The following is a description of a gene set: species: Homo sapiens Any process that modulates the frequency, rate or extent of T cell activation. Human Gene Set: GOBP_REGULATION_OF_T_CELL_ACTIVATION, and this is the list of marker genes: SMARCD3, CD274, CYRIB, SASH3, PLA2G2F, EBI3, BID, IL36B, IL10, KAT2A, RIPOR2, HLA-DRB3, LGALS9C, BTLA (B and T lymphocyte associated), HLA-DRA, NR5A2, CD40LG, DLG5, NLRP3, TNFSF14, FANCD2, BRD4, TRAF6, SELENOK, CD37, CD28, ADAM8, XBP1 (X-box binding protein 1), CD4, LCK, CD46, RAC2, PIK3R6, SIRPA, SHH, ZC3H8, RASGRP1, BCL10, VNN1, CD80, SHB, ZP4, MIR181C, FBXO38, RUNX3, IL20RB, IL12A, ZNHIT1, SMARCE1, SLC46A2, CD209, HES1, CRTAM, VTCN1, BCL6, KLHL22, SOX12, IL27, HLA-DRB4, LGALS1, TYK2, AGER, KLRK1, DUSP22, LEP, CTLA4, CBFB, CD55, PRDX2, CD74, LEF1, LAT, KITLG, TSPAN32, FGL2, CTSG, NOD2, HLA-DRB5, ABL2, LAG3, NCK1, MARCHF7, CGAS, LAPTM5, CD276, STAT5B, CARD11, FANCA, SOX13, THY1, NCKAP1L, IL1A, IGFBP2, MALT1, IL15, MIR27A, IL1RL2, HSPD1, LOXL3, HLA-E, CD70, TCF7, YWHAG, SMARCD2, SOD1, TNFAIP8L2, DNAJA3, CCL2, CASP3, TESPA1, VSIR, SMARCB1, SPN, NDFIP1, RHOA, IL12B, TFRC, CD81, PAG1, PRKAA1, IL23A, HLA-DOB, RAG1, GLMN, PRNP, ZBTB1, ACTB, HLA-DRB1, PRDM1, IL18, SIRPB1, EPO, KCNK18, KLHL25, IL4I1, SRC, CD47, ITPKB, MIR30B, IRF4, PRELID1, CD160, PTPRC, EFNB1, VCAM1, VAV1, DOCK8, HLA-DMB, IL4R, GLI2, ABL1, HSPH1, GPR65, CSK (NCBI Gene Id 1445), ZNF683, RIPK3, RC3H2, MTOR, IRF1, RIPK2, UFL1, CCR7, AMBRA1, CCL21, TNFSF13B, EGR3, ASCL2, AP3B1, SLC4A2, RC3H1, RHOH, ILDR2, TNFSF11, FYN, AIF1, SCRIB, BTN2A2, SIT1, PTPN11, ARG2, ARID2, HLA-G, IL2, KAT5, GLI3, ZMIZ1, NFKBID, GATA3 (NCBI Gene Id 84828), CORO1A, HFE, CDKN2A, PDCD1, ADA, OPA1, CCL19, TMEM131L, NFKBIZ, STAT5A, ERBB2 (erb-b2 receptor tyrosine kinase 2), IDO1, DTX1, CAMK4, SFTPD, ARG1, SPTA1, HLA-DQB1, ACTL6B (actin like 6B), KLRC4-KLRK1, BATF, SDC4, JAK3 (NCBI Gene Id 3718), ZAP70, BMP4, SMARCA2, PTPN22, AKT1, LYN, PTPN2, PAWR, IL7 (interleukin 7), TREX1, IL21, ITCH, CR1, TGFBR2, DPP4, PHF10, CTNNB1, ICOS, HLX, CCDC88B, IL7R, SYK, HHLA2, CYLD, CLC, TBX21, RAG2, PDCD1LG2, LILRB2, CCR2 (NCBI Gene Id 90262), ICOSLG, DLG1, CD27, RUNX1, IL4, PPP3CA (NCBI Gene Id 5530), ARID1B, XCL1 (NCBI Gene Id 92337), IL12RB1, IL2RG, GNRH1, LAX1, LGALS3, ACTL6A, LGALS9, TMIGD2, SOS1, RPS3, IL6, IL6ST, CD1D, PCK1, ZP3 (NCBI Gene Id 7785), PYCARD, CD69, MIR21, DHPS, PSG9, LILRB4, SIRPG, TNFRSF21, YES1, HLA-DQA2, CLEC4G, HLA-DPB1, CD3E, IFNB1, HLA-DQB2, B2M, CAV1, BRAF, MDK, DROSHA, NCK2, TARM1, SOX4, TOX, SH3RF1, SMAD7, BRD7, CEBPB, PBRM1, SMARCC1, LILRB1, LGALS9B, CD86, MAP3K8, PRKCQ, LRRC32, HLA-DMA, HLA-DOA, FLOT2, TNFRSF1B, FOXJ1, AP3D1, TNFSF9, CD300A, PLA2G2D, ARID1A, PDPK1, PRKCZ, PLA2G2A, IFNL1, HLA-DPA1, BMI1, TNFSF4, ZBTB16, CBLB, CD24, SOS2, DUSP3, TIGIT, PELI1, SMARCA4, CD5, VSIG4, TWSG1, CLECL1P, IGF2, SMARCC2, TNFSF18, TNFSF8, DUSP10, CD2, JAK2, CCL5, PLA2G5, PNP, GPNMB, SART1, MAD1L1, BRD2, IFNG, FCHO1, HAVCR2, ZEB1, EP300, RARA, CD6, NKAP, GPAM, IFNA2, WNT10B, SCGB1A1, HLA-A, BAD, JUNB, SMARCD1, FOXN1, LGALS8, FOXP3 (forkhead box P3), EFNB2, TNFRSF9, FGL1, PIK3CD, TNFRSF13C, IL1B, SPINK5, SOCS6, MAPK8IP1, TNFRSF14, IHH, FADD, HLA-DQA1 (NCBI Gene Id 7946), BTNL2, IL23R, ZC3H12A, SOCS5, TGFB1, LMO1, SOCS1, SLAMF1 (signaling lymphocytic activation molecule family member 1), CYP26B1, PRKAR1A, EFNB3, CLPTM1, IGF1, METTL3, HMGB1, ANXA1 (NCBI Gene Id 301), RASAL3, SLC7A1, FOXO3, IL2RA, DAPL1, CD83, NRARP, ADORA2A (NCBI Gene Id 135), PTPN6, ZBTB7B